Given this list of marker genes Malt1 (NCBI Gene Id 240354), Cd19, Slamf8, Plcl2, Nfatc1, Dpp4, Cmtm7, here is a description of the gene set: species: Mus musculus The process in which a hemopoietic stem cell acquires the specialized features of a B-1 B cell. B-1 B cells are a distinct subset of B cells characterized as being CD5 positive, found predominantly in the peritoneum, pleural cavities, and spleen, and enriched for self-reactivity. Mouse Gene Set: GOBP_B_1_B_CELL_DIFFERENTIATION